Given this list of marker genes GDF15, GFRAL, COL6A1, PRLH, C1QTNF4 (C1q and TNF related 4), NMUR2, RMI1 (RecQ mediated genome instability 1), CNTN2, GUCA2B, here is a description of the gene set: studied in species Homo sapiens Human Gene Set: GOBP_REDUCTION_OF_FOOD_INTAKE_IN_RESPONSE_TO_DIETARY_EXCESS An eating behavior process whereby detection of a dietary excess results in a decrease in intake of nutrients.